The following is a description of a gene set: Human Gene Set: HP_PYRIDOXINE_RESPONSIVE_SIDEROBLASTIC_ANEMIA studied in species Homo sapiens Pyridoxine-responsive sideroblastic anemia A type of sideroblastic anemia that is alleviated by pyridoxine (vitamin B-6) treatment., and this is the list of marker genes: FANCI (FA complementation group I), FANCL, UBE2T, FANCM, RFWD3, RAD51 (NCBI Gene Id 5888), BRCA1, FANCF, MAD2L2, BRIP1, FANCA, FANCD2, PNPO, FANCE, FANCC, FANCB, PALB2, ERCC4, XRCC2, RAD51C, FANCG, SLX4, BRCA2